Given this list of marker genes Hspa1b, Ms4a4b, Ltb, Crip1, Klf6, Igkc, Fos (NCBI Gene Id 14281), Btg2, Jun, Hspa1a, Cd74, here is a description of the gene set: Cytokines mediate cell-cell communication in the immune system and represent important therapeutic targets. A myriad of studies have highlighted their central role in immune function, yet we lack a global view of the cellular responses of each immune cell type to each cytokine. To address this gap, the authors created the Immune Dictionary, a compendium of single-cell transcriptomic profiles of more than 17 immune cell types in response to each of 86 cytokines (>1,400 cytokine-cell type combinations) in mouse lymph nodes in vivo. A cytokine-centric view of the dictionary revealed that most cytokines induce highly cell-type-specific responses. For example, the inflammatory cytokine interleukin-1β induces distinct gene programmes in almost every cell type. A cell-type-centric view of the dictionary identified more than 66 cytokine-driven cellular polarization states across immune cell types, including previously uncharacterized states such as an interleukin-18-induced polyfunctional natural killer cell state. studied in species Mus musculus Mouse Gene Set: CUI_T_CELL_CD4_OSM_RESPONSE_DN from publication Cui A, Huang T, Li S, Ma A, Pérez JL, Sander C, Keskin DB, Wu CJ, Fraenkel E, Hacohen N (PMID 38057668) Genes negatively differentially expressed in cell type: CD4+ T cell upon treatment with cytokine: OSM in mouse lymph nodes in vivo.